Given this list of marker genes HUS1B, RSPH1, NCAPH, PSMC3IP, KIFAP3, FAM9C, SUV39H1, NCAPD3 (NCBI Gene Id 23310), NIFK, RAD21, RCC1, SYCP2, REC8, HSPA2, CCNB1IP1, RAD9A, NEK2, SYCE3, NCAPH2, P3H4, BRD4 (bromodomain containing 4), CDX2, TEX12 (NCBI Gene Id 56158), INCENP, FKBP6, ADD3, SMC4, TEX11, H3-4, HUS1, SYCP1, SMC3, HORMAD1, SMC1A, PLK1, SMC2, RGS12, SYCE1L, TTN, UBE2I, NCAPD2, C14orf39, RAD51, RAD50, RPA1, NCAPG (non-SMC condensin I complex subunit G), STAG3, MEI4, KASH5, SYCE1, RNF212, BRCA1, TOPBP1, TUBG1, MLH1, H2AX, CHMP1A, AGO3 (NCBI Gene Id 79910), SHOC1, NOL6, MSH4, FAM9B, SUN2, DNMT3L, DMC1, SMC1B, MLH3, HORMAD2, RRS1, IHO1, RNF212B, SYCP2L, RAD9B (RAD9 checkpoint clamp component B), SYCE2, LRPPRC, BRCA2, BLM, RAD1, SYN1, NCAPG2, CHEK1, FAM9A, SYCP3, here is a description of the gene set: studied in species Homo sapiens Human Gene Set: GOCC_CONDENSED_NUCLEAR_CHROMOSOME A highly compacted molecule of DNA and associated proteins resulting in a cytologically distinct nuclear chromosome.